The following is a description of a gene set: Mouse Gene Set: GOBP_SIGNAL_RELEASE The process in which a signal is secreted or discharged into the extracellular medium from a cellular source. species: Mus musculus, and this is the list of marker genes: Stim1, Septin5, Tgm2, Trpv6, Gal, Inhba, Kcnh1 (potassium voltage-gated channel, subfamily H (eag-related), member 1), Dio2, Syt12, Vdr, Fam3b, Vsnl1, Kiss1r, Sstr5, Fgb, Kcnj11, F2rl1, Trim9, Stxbp4, Gpr158, Cplx3, Rims1, Ncoa6, Plcd1, Kcnq1, Bglap2, Kcna2, Stx4a, Xlr4b (NCBI Gene Id 27083), Cga, Vps35, Tnfrsf11a, Ube2q1, Cplx4, Atp5pf, Wnt7a, Ppfia2, Mafa, Hcfc1, Trpm5, Gcg, Cpe, Kcnk9, Sybu, P2ry1, Osbpl2, Bglap, Sv2b, Sucnr1, Glud1, Madd, Syp, Mup2, Myrip, Stx1a, Erc1, Tacr2 (NCBI Gene Id 21337), Slc8b1, Gpr151, Cask, Oprk1, Ppfia3, Mef2c, Gnai1 (G protein subunit alpha i1), Tspoap1, Cry2, Trpc1, Sptbn2, Klf7, Prkn (NCBI Gene Id 50873), Kif5b, Cyp2j5, Fbxo45, Tprg1l, Ltbp4, Tac1, Arrb1, Irs2, Nkx6-1, Hcar2, Nmu, Prrt2, Kcnj8, Xbp1, Fga, Adipoq, Rhot1, Ngf, Syt2, Hmgcr, Rest, Btk, Rab8b, Acvr2a, Cd300a, Fmr1, Cxcl12, Syt8, Chrm3 (cholinergic receptor, muscarinic 3, cardiac, NCBI Gene Id 12671), Adam8, Lrrc8a, Bcl2l1, Snca, Gipr, Ptprv, Pla2g10, Ptpmt1, Gip, Mpc2, Pparg, Fcer1a, Runx1, Foxo1, Rph3al, Mif, Trpm4, Pax8, Rims4, Snord35a, Dgki, Crhbp, Syt7, Pnkd, Mup1, Egfr, Mcu, Oxct1, Adcy5, Brsk1, Birc5, Pclo, Hnf1b, Maob, Nppa, C1qtnf1, Ghrhr, Snapin, Scg5 (NCBI Gene Id 98920), Fam3a, Ndufaf2, Cacna1b, Ren1, Gpr119 (G-protein coupled receptor 119), Cyb5r4, Pfkl, Lin7b, Sox11, Ccdc186, Tnfsf11, Sirt6, Ptpn11, Slc4a8, Slc6a9, Pfkfb2, Cd38, Map4k4, Sncg (synuclein, gamma), Abat, Gata3, Snap91, Prkaca, Slc18a3, Htr1a, Myh9 (NCBI Gene Id 97972), Ghsr, Mapk9, Snord32a, Slc16a2, Itpr1, Prkcb, F2rl2, Exoc3l, Stx1b, Best1, Plcb1, Cry1, Crhr2, Git2, Cspg5, Scrib (NCBI Gene Id 54559), Vps18, Pla2g4a, Nf1, Htr1d, Niban2, Ucn, Abcc4 (NCBI Gene Id 239273), Nos2, Fcer1g, Bmal1, Aacs, Mir200a, Eipr1, Pdzd11, Ptbp1, Rfx6, Pfkm, Kiss1, Tnf, Neurod1, Ucn2, Rap1b, Wnk4, Gdf9, Pck2, Gna11, Ppp3cb, Rph3a, Doc2b, Mtnr1b, Sirt3, Drd2, Lif, Stx2, Camk2n1 (NCBI Gene Id 66259), Acsl4, Ptgs2, Tfr2, Abca1, Nell2, Htr1b, Tfap2b, Braf, Ppt1, Slc44a4, Rfx3, Tardbp, Rab3gap1, Il1a, Gpr27, Igfbp3, Ffar3, Xlr4a (NCBI Gene Id 630479), Adcyap1, Micu3, Nrg1, Uqcc2, Mup5, Sphk1, Rab11fip5, F2, Syt5, Snap47, Tmf1, Vip, Prkcg, Edn3, Git1, Gabbr1, Fgfr1, Adora2a, Stx11, Rab44, Slc16a10, Gnas, Nr1d1 (nuclear receptor subfamily 1, group D, member 1), Syt9, Ggcx, Rbp4, Il11, Eny2, Stxbp5, Ghrl, Gper1, Kcnc3, Slc38a2, Hadh, Zbed6, P2ry2, Erc2, Sirt1, Cpt1a, Gja5, Spp1, Tacr1, Rab11b, Psmd9 (proteasome (prosome, macropain) 26S subunit, non-ATPase, 9, NCBI Gene Id 74214), Foxl2, Hmgn3, Snx4, P2rx2, Mup4, Htr7, Anxa5, Osbp, Smpd3, Slc30a8, Syt11, Ncs1, Creb1, Comt, Osm, C1qtnf3, Trpv4, Prkce, Tiam1, Orai1, Serp1, Nnat, Rab11fip1, Casr, Ptgs1, Mir410, Capn10, Nucb2, Ptger4, Mctp2, Dgat1, Sv2a, Oga, Tcirg1, Sidt2, Gnaq, Kcnn4, Trpm2, Slc18a1, Cacna1d, Nisch, Entpd1, Slc9b2, Ucp2, Slc2a2, Ensa, Selenot, Alox5, Ptger3, Cacnb4, Selenom, Dynll1, Arhgef7, Syt1, Kpna4, Kcnc4, Rbm4, Tcf7l2, Syt13, Rasl10b, Clock, Pfn2, Raf1, Doc2g, P2rx7, P2rx1, Agtr2, Cltrn, Kdm5b, Slc18a2, Npy2r, Hnf4a, Nadk, Fzd4, Bmp6 (bone morphogenetic protein 6), Jagn1, Gpr68, Snord34, Pla2g6, Abca12, Pask, Abcg1, Adra2a, Snap29, Sct, Ccl5, Agtr1a, Fto, Ppp1r9a, Rims3, Lep, Fgf23, Ppard (peroxisome proliferator activator receptor delta), Stxbp1, Lgals3 (NCBI Gene Id 16854), Hif1a, Rtn4, Fam3d, Acvr2b, Drd3 (dopamine receptor D3), Nos1, Syt10, Mctp1, Rab11fip2, Crh, Gpr39, Ffar4, Cntf, Chrnb2, Slc6a4, Unc13a, Cdk16, Stxbp5l, Pink1, Midn, Ywhaz, Efr3a, Prkar1a, Ptpn23, Inhbb, Rapgef4, Nrxn3, Htt, Hfe, Hnf1a, Rimbp2, Nr1h4, Epha5, Cnr1, Rab1a, Chrna3, Lrrk2, Gnaz, Cyp19a1, Gpld1, Slc25a22, Stx19, Dnm1l, Sirt4, Glul, Ppp3ca, Anxa7, Htr6, Mc4r, Syde1 (NCBI Gene Id 71709), Hcrt, Sytl4, Rap1a, Rac1, Ffar2, Syn3, Uts2, Acvr1c, Pick1, Fgfr4, Dvl1, Or51e2, Rab5a, Nr4a1, Cplx2, Porcn, Brsk2, Mup3, Cacna1e, Tm7sf3, Prkca, Sfrp1, Chga (NCBI Gene Id 12652), Htr2a, Slc30a1, Cckar, Drd4, Ctbp2, Smad2, Park7, Agt, Il6, Cftr, Synj1, Sncaip, Npy1r, Snord33, Hmga2, Isl1, Ucn3, Ednrb, Galr1, Gprc6a, C1qtnf12, Prepl (NCBI Gene Id 77396), Fkbp1b, Aqp1 (NCBI Gene Id 11826), Anxa1, Pcp4, Cadps2, Tunar, Ffar1, Mlxipl, Dab2, Pex5l, Adcy8, Ifng, Lepr, Ica1, Ptprn2, Nrxn1, Adora2b, Ptprn, Blk, Adora1, P2ry4, Hmga1, Mtnr1a, Adora3, Cela2a, Psen1, Fbxl20, Adam17, Bad, Rab11fip3, Ano1, Snx19, Nr0b2, Pomc, Nkx3-1, Nlgn1, Slc16a1, Cckbr, Clcf1, Il1b, Retn, Otof, Tbx3, Edn1, Baiap3, Lin7a, Il1rn, Sv2c, Grik5, Grm8, Mfn2, Napa (NCBI Gene Id 67002), Pak1, Prkd1, Oxt, Stxbp2, Tmem132a, Ildr2, Gja1, Cacna1c, F2r, Pde4c, Syk, Trh, Nrxn2, Gnao1, Vgf, Foxa2, Htr2c, Cartpt, Itsn1, Pde3b, Myo5a, Rims2, Ccn3, Foxd1, Nlgn2, Pim3, Camk2a, Aimp1, Edn2, Dtnbp1, Jak2, G6pc2, Mir130a, Lrp1, Gck, Grp, Tbc1d1, Kmo (kynurenine 3-monooxygenase), Hrh3, Apln, Asic1, Npff, Kcnj6, Pde1c, Syn2, Sri, Fcgr3, Sox4, Cacna1a, Inha, Grm2, Glp1r, Ghrh, Stxbp3, Vamp2, Pdx1, Lyn, Cplx1, C2cd2l, Vamp8, Chrna4, Efna5, Ptges, Unc13b, Chd7, Chrna6, Npy, Irs1, Kcnb1, Trpa1, Smad4, Fgg, Syt4, Lin7c, Chrna7, Piwil4, Rab3a, Ildr1 (NCBI Gene Id 106355), Vamp1 (vesicle-associated membrane protein 1), Pde8b, Per2, Unc13c, Ecrg4, Doc2a, Syngr3, Kalrn (NCBI Gene Id 72378), Npvf, Crhr1, Napb, Gnat1, Rptor, Myb, Pla2g3, Map2k6, Atp2a2 (ATPase, Ca++ transporting, cardiac muscle, slow twitch 2), Oxtr, Fbn1, P2ry12, Lrp5, Ntrk2, Cyp27b1, Tspo, Mup11, Abcc8, Snap23, Snap25, Syn1, Myt1, Atg7, Cadps, Srebf1, Oprm1, Wls, Nmb